The following is a description of a gene set: The transcription factor FoxP3 partakes dominantly in the specification and function of FoxP3+ CD4+ T regulatory cells (Tregs), but is neither strictly necessary nor sufficient to determine the characteristic Treg transcriptional signature. Computational network inference and experimental testing assessed the contribution of several other transcription factors (TFs). Enforced expression of Helios or Xbp1 elicited specific signatures, but Eos, Irf4, Satb1, Lef1 and Gata1 elicited exactly the same outcome, synergizing with FoxP3 to activate most of the Treg signature, including key TFs, and enhancing FoxP3 occupancy at its genomic targets. Conversely, the Treg signature was robust to inactivation of any single cofactor. A redundant genetic switch thus locks-in the Treg phenotype, a model which accounts for several aspects of Treg physiology, differentiation and stability. from publication Fu W, Ergun A, Lu T, Hill JA, Haxhinasto S, Fassett MS, Gazit R, Adoro S, Glimcher L, Chan S, Kastner P, Rossi D, Collins JJ, Mathis D, Benoist C (PMID 22961053) Human Gene Set: GSE40274_CTRL_VS_FOXP3_AND_GATA1_TRANSDUCED_ACTIVATED_CD4_TCELL_DN Genes down-regulated in CD4 T conv: control versus over-expression of GATA1 and FOXP3. species: Homo sapiens, and this is the list of marker genes: MTTP, H1-2, CNOT9, COX6B2, ZFP69, PKHD1L1, PRX, SLC4A1, ABCB6, MKI67, VPREB3, CIAPIN1 (cytokine induced apoptosis inhibitor 1), ANKLE1, HEBP1, HYAL3, MKRN3, RETSAT, BIN3 (NCBI Gene Id 55909), RFX2, MYH10, SDC4, GLS2, LIPK, MICALL2, HMBS, REEP6, PYCR3, TMEFF1, BTNL10P, CTSG, PFKM, GLRX5, LAGE3, TSPAN8 (NCBI Gene Id 7103), CPA2, RRM1, PIR, EPCAM, ALPG, OLFML1, FADS1, NUP37, DNAJC25, PRKAR2B, PPDPF, DNTT, MXRA8, IL1RL1, SAXO2, HOXD9, GCLM, WDR18, IFRD2, TRIM10, USP49, NME4, TIGD3, OPN3, CEP170B, HAUS1, TBC1D2, B3GLCT, TMEM183A, RGS9BP, TSPO2, BLVRB, STOML1, ZSCAN10, BSG, TGM1, AQP11 (NCBI Gene Id 282679), AIP, CDC6, MDK, ANKRD9, AGPAT2, FPR1, MRPS28, DRAM1, F7, CHADL, RHAG, ARHGDIG, ANK1, SOWAHA, ZNF483, TLCD2, CD40, ILDR2, HEMGN, HSPA9, SH2D4A, WDR17, C1QTNF1, GABRA6, SPIRE1, TUBG1, FEM1B, FNDC11, SLC41A3, ADCY6 (NCBI Gene Id 23320), RANGRF, PEG10, GATA1, IFI30, RPF1, LRIT3, RBM8A (NCBI Gene Id 9939), TRAPPC2L, SIGLEC1, TROAP, EIF3G, SLC29A1, REPIN1, LHFPL2, LMNA, HS3ST5, COX4I2, PSMD9, PRTN3, URB2, GTSE1, RLN3, SOX6, SLBP, NFIC, GEMIN4, COA4, SGO1, CCNA2, ATP5MC1 (NCBI Gene Id 516), AURKA, BCL2L14, PHYHIP, SNAP25, ALDH1A1, HS3ST2, LRRC27, CSRP1, ABCD3, ZBTB22, PMF1, PIDD1, PCYT1B, PLVAP, SVBP, TIPIN, PHLDA2, TFPI (NCBI Gene Id 7035), KIF22